Given this list of marker genes Tob1, Grb10, C1ra, Ccng1, Trp53inp1, Txnip, Tmem185a, Lrrc2, Sertad1, H2aj, Ei24, Csrnp2, Trafd1, Ulk1, Btg2, Carhsp1, Pmm1, Lpin1, Zfp36l1, Tpp1, Cbs, Nectin4, Cd53, Nudcd2, Cdkn1a, Pierce1, here is a description of the gene set: DNA microarrays are powerful tools for the analysis of gene expression on a genomic scale. The importance of individual regulatory events for the process under study can however not be deduced unequivocally without additional experiments. We devised a strategy to identify central regulators of cancer drug responses by combining the results of microarray experiments with efficient methods for phenotypic testing of candidate genes. We exposed murine FL5.12 pro-B cells to cisplatin, camptothecin, methotrexate or paclitaxel, respectively and analysed the patterns of gene expression with cDNA microarrays. Drug-specific regulatory events as well as intersections between different apoptotic pathways, including previously studied responses to staurosporine and interleukin-3 (IL-3) deprivation, were identified. Genes shared by at least three pathways were chosen for further analysis. Ectopic expression of three such genes, TEAP, GP49B, and Lipin1 was found to have an anti-proliferative effect on pro-B cells. Interestingly, we identified hemoglobin alpha as a strong pro-apoptotic regulator. While hemoglobin-expressing cells were growing normally in the presence of IL-3, they displayed accelerated apoptosis with similar kinetics as Bax overexpressing cells upon IL-3 removal. The pro-apoptotic effect of hemoglobin was suppressed by Bcl-2 and was characterized by enhanced stimulation of caspase activity. studied in species Mus musculus Genes specifically up-regulated in FL5.12 cells (pro-B lymphocyte) by camptothecin. Mouse Gene Set: BRACHAT_RESPONSE_TO_CAMPTOTHECIN_UP from publication Brachat A, Pierrat B, Xynos A, Brecht K, Simonen M, Brüngger A, Heim J (PMID 12447701)